Given this list of marker genes CCL3 (C-C motif chemokine ligand 3), CCL7, CXCL1, CXCL3, XCL1, CCL4, CCL14, CXCL12, CCL23, CCL11, CCL13, CX3CL1, CXCL13, CXCL14, CCL22, GPR15LG, CCL2, CCL27, CCL1, CXCL6, C5, CCL24, CCL18, CXCL10, CXCL5, CCL20, CXCL11, PPBP, CCL5, XCL2, CXCL8, CXCL2, CCL4L2, CCL21, CCL17, CCL15, CXCL16, CCL26, CKLF, CCL19, CCL8, CCL16, PF4V1, PF4, CXCL9, CCL25, CCL3L3, CCL28, here is a description of the gene set: Human Gene Set: GOMF_CHEMOKINE_ACTIVITY studied in species Homo sapiens The function of a family of small chemotactic cytokines; their name is derived from their ability to induce directed chemotaxis in nearby responsive cells. All chemokines possess a number of conserved cysteine residues involved in intramolecular disulfide bond formation. Some chemokines are considered pro-inflammatory and can be induced during an immune response to recruit cells of the immune system to a site of infection, while others are considered homeostatic and are involved in controlling the migration of cells during normal processes of tissue maintenance or development. Chemokines are found in all vertebrates, some viruses and some bacteria.